The following is a description of a gene set: species: Mus musculus Mouse Gene Set: REACTOME_INITIAL_TRIGGERING_OF_COMPLEMENT Initial triggering of complement, and this is the list of marker genes: Ighv8-2, Igkv2-112, Ighv6-3, Ighv6-6, Crp, C1qb, Ighv3-8 (NCBI Gene Id 780831), Ighv3-3, Ighv8-9, Cfb, Ighv8-13, Igkv2-109, Ighv5-16, C2, Mbl2, Ighv7-3, Ighv8-6, Fcnb, Ighv5-15, Ighv5-2, Ighv3-1, Igkv15-103, Igkv1-131, Gzmm, Igkv1-35, Igkv1-88, Igkv1-133, Igkv11-125, Ighv6-5, C1s2 (NCBI Gene Id 317677), Igkv1-135 (NCBI Gene Id 243420), Colec11, Ighg1, Iglc1, Ighv8-4, Ighv5-9-1, Ighv6-4, Ighv5-17, Igkv1-110, C3, Ighv7-2, Ighv8-11, Ighv3-6, Igkv16-104, Ighv8-8, Ighv3-5, Igkv1-132, Cfp, Ighv16-1, Igll1, Ighv5-4, Ighv13-2, Ighv5-12, Igkv1-117, Ighv7-4, Ighv12-3, Iglc2, Igkv17-121, Ighv5-6, Igkv1-99, Igkv1-122, Ighv8-12, Cfd, Colec10 (NCBI Gene Id 239447), Ighg3, C1qa, Igkv2-137, Ighv5-9, Ighv8-5, C1qc, Ighg2c, Masp2, Ighv5-12-4, Igkv20-101-2, Fcna, Igkv8-21, Igkv18-36, C4b, Masp1, Ighv6-7, Ighv3-4, C1ra